Given this list of marker genes NUP37, NDC1, SEC13 (NCBI Gene Id 6396), RAN, NUP210, NUP98, NUP62, rev, NUP107, RANBP2, NUP50, NUP85, NUP160, NUP214, POM121 (NCBI Gene Id 9883), RAE1, AAAS, NPM1, NUP42, RCC1, NUP43, NUP205, TPR, POM121C, KPNB1, NUP93, NUP88, NUP58, NUP35, NUP133, NUP155, NUP54, NUP153, NUP188, SEH1L, here is a description of the gene set: species: Homo sapiens part of: Interactions of Rev with host cellular proteins Nuclear import of Rev involves the cellular proteins including importin-beta and B23 and is mediated by an arginine-rich nuclear localization signal (NLS) within the RNA binding domain of the Rev protein. The NLS of Rev associates with importin- beta as well as B23 which has been shown to function in the nuclear import of ribosomal proteins. The Rev-importin beta-B23 complex associates with the nuclear pore through interactions between importin beta and nucleoporin. Upon entry into the nucleus, Ran-GTP associates with importin beta resulting in in the disassembly of the importin beta-Rev-B23 complex and the release of Rev cargo. Reactome Pathway: Nuclear import of Rev protein